The following is a description of a gene set: Human Gene Set: GOBP_POSITIVE_REGULATION_OF_LAMELLIPODIUM_ASSEMBLY species: Homo sapiens Any process that increases the rate, frequency or extent of the formation of a lamellipodium, a thin sheetlike extension of the surface of a migrating cell., and this is the list of marker genes: ACTR3, CARMIL2, AKIRIN1, RAC1, TWF2, NCKAP1, ABI2, AUTS2, BRK1, PLCE1, PIK3CA, FRMD7, CLRN1, RAC2, PIK3R1, ARPC2, WNT1, HSP90AA1, MTOR, CDC42, MSTN, AVIL, CFL1, ACTR2, WASF2, OCLN, CYFIP1, FSCN1 (fascin actin-bundling protein 1)